Given this list of marker genes Crb3, Crb1, Mpdz, Crb2, Patj, here is a description of the gene set: Mouse Gene Set: GOCC_SUBAPICAL_COMPLEX studied in species Mus musculus The most apical region of the lateral plasma membrane of an invertebrate epithelial cell. The subapical complex lies above the zonula adherens and the septate junction, and is comparable to the position of the tight junction of vertebrate cells.